Given this list of marker genes LIMD2, ITPRIP, ACAP1, NFIL3, CCRL2, MCEMP1, GABBR1, RILPL2, OSM, LONRF3, RAB3D, ASGR1, MTMR11, MXD1, DYRK3, TREM1, CST6, FGR, SOHLH1, ATP2A3, CREB5, S1PR4, TANGO6 (NCBI Gene Id 79613), PFKFB3, CLEC5A, SGMS2 (NCBI Gene Id 166929), DPEP2, PLAUR, STK26, BCL2A1, GK3, ETF1, IL1B, NLRP12, MAP2K3, ADA, MACROH2A1 (macroH2A.1 histone), PHLDA1, ARHGAP26, KDM6B, DUSP2, TRAF1, GLIPR2, IL27RA, TIFAB, DOCK5, IGF2BP2, CD244, ITGAX, BIRC3, MMP12, SELL, MBOAT2, PPARG, RAB27A, ADAM8, CD1C, CTNNBL1, DUSP10, LYZ, S100A12, GRK6, GPR183, RIPK2, LITAF, PRKCH (NCBI Gene Id 79030), NDEL1, CD48, SIK1, CCL18, EDEM1, HCAR3, MMP19, FABP5, PTGER2, AMPD2, FLT3, CXCL2, CYTIP, SLCO4A1, USP3, CLMN, ABTB3, NAMPT, LILRA1, STK17B, KCNN4, FRAT1, RASSF5, FCN1 (ficolin 1), CSTA, TMEM88, SDS, NRIP3, ZNF331, TAMALIN, MIR3945HG, LTA4H, VWCE, ARL8B, PPIF, CCR2, OPN3, SERPINA1, MARCO, PFKFB4, FA2H, CCL7, GPAT3, TNFAIP3, OLR1, P2RX1, TMTC2, LGALS2, PTP4A2, TNIP3, PFKP (NCBI Gene Id 5214), PGAM1, DHRS9, MTHFD2, SLC25A37, AQP9, LINC00937, ELF4, STK39, IFFO2, PRAME, S100A10, VPS37C, JAKMIP2, SRA1, SLAMF7, CXCL5, SLC46A2, AREG, SEMA4A, VEGFA, GK, NRGN, RIPOR2, CD1D, CD72, EHD1, NLRP3, CXCL3, TAGLN2 (NCBI Gene Id 8407), SIRPB1, LPL, OLIG1, CSTB, CATSPER1 (NCBI Gene Id 117144), LINC00922, UPP1, PDLIM7, WTAP, MGAM, CCDC83, IL1RN, MALT1, C15orf48, CSGALNACT2, CLEC4E, NOD2 (NCBI Gene Id 8135), DCANP1, F5, KBTBD11, PRAM1, PLIN2, CCL20, CFP, PLAC8, ACP3 (NCBI Gene Id 55), DNAAF1, CCDC88C, DDX21, FRY, PTPRE, TNFRSF10B, LRG1, ZMIZ1, PLP2, PADI2, CD52, CAMSAP1, FTH1P5, AATBC, APOBEC3A, ICAM3, EREG, GGT1, ZNF697, C11orf21, SLC16A6, MAPKAPK3, CLEC10A, CD1B, FCRLB, here is a description of the gene set: species: Homo sapiens Conditional macrophage-specific PPARg knockout mice were generated on C57Bl/6 background by breeding PPARg fl/- (one allele is floxed, the other is null) and lysozyme Cre transgenic mice. PPARg and IL-4 signaling was analyzed on bone marrow-derived macrophages. Bone marrow of 3 mice per group was isolated and differentiated to macrophages with M-CSF (20 ng/ml). 20 ng/ml IL-4 was used to induce alternative macrophage activation and 1 uM Rosiglitazone (RSG) was used to activate PPARg. From each mouse 4 samples were generated: 1. M-CSF, 2. M-CSF+RSG, 3. IL-4 and 4. IL-4+RSG. All compounds were added throughout the whole differentiation process, and fresh media was added every other day. Control cells were treated with vehicle (DMSO:ethanol). After 10 days, RNA was isolated and gene expression profiles were analyzed using Mouse Genome 430 2.0 microarrays from Affymetrix. from publication Szanto A, Balint BL, Nagy ZS, Barta E, Dezso B, Pap A, Szeles L, Poliska S, Oros M, Evans RM, Barak Y, Schwabe J, Nagy L (PMID 21093321) Human Gene Set: GSE25123_CTRL_VS_ROSIGLITAZONE_STIM_PPARG_KO_MACROPHAGE_UP Genes up-regulated in bone marrow-derived macrophages with PPARG knockout: control versus rosiglitazone.